The following is a description of a gene set: Mouse Gene Set: TABULA_MURIS_SENIS_LUNG_NK_CELL_AGEING from publication Tabula Muris Consortium (PMID 32669714) studied in species Mus musculus, and this is the list of marker genes: Rps9, H2-K1, Tle5, Gimap7 (NCBI Gene Id 26967), Bcl2, Rps14, Cdkn2c, H1f4 (NCBI Gene Id 50709), Klf6, Rpl17, Rps24, Tpt1, Rpl10, Psmb8, H2-Q4, Rps16, Scgb1a1, Rps5, S100a6, Ltb, Rps10, Nop53, H2-Ab1, Rps20, Cldn5, B2m, Rpl12, Rpsa, Rpl18a, Rpl6, Rpl29, Rps6, Rps15, Rpl18, Rpl32, Rps12, Pdia3, Xist, Rpl21, Rps19, Rps18, S100a4, Ly6e, Cd74, Rpl8, Rpl13, Rps3, Rpl23, Rpl14, Rps3a1, Vps37b, Rpl3, Rpl23a, Pim1, Uba52, Rpl13a, Rpl19, Rpl4, Rps4x, Rpl35, Rps7, Hspa5, Yy1, Rplp0, Lgals3